The following is a description of a gene set: studied in species Mus musculus Genes up-regulated in 3T3 cells (fibroblast) upon activation of JNK pathway. from publication Han SY, Kim SH, Heasley LE (PMID 12354774) Human Gene Set: HAN_JNK_SINGALING_UP The c-Jun N-terminal kinases (JNKs) are encoded by three genes that yield 10 isoforms through alternative mRNA splicing. The roles of each JNK isoform in the many putative biological responses where the JNK pathway is activated are still unclear. To examine the cellular responses mediated by different JNK isoforms, gain-of-function JNK1 polypeptides were generated by fusing the upstream mitogen-activated protein kinase kinase, MKK7, with p46JNK1alpha or p46JNK1beta. The MKK7-JNK fusion proteins, which exhibited constitutive activity in 293T cells, were stably expressed in Swiss 3T3 fibroblasts using retrovirus-mediated gene transfer. Swiss 3T3 cells expressing either of the MKK7-JNK polypeptides were equally sensitized to induction of cell death following serum withdrawal. To search for other cellular responses that may be selectively regulated by the JNK1 isoforms, the gene expression profiles of Swiss 3T3 cells expressing MKK7-JNK1alpha or MKK7-JNK1beta were compared with empty vector-transfected control cells. Affymetrix Genechips identified genes for which expression was increased in MKK7-JNK-expressing cells relative to vector control cells. Twenty genes including those for c-Jun, MKP-7, interluekin-1 receptor family member ST2L/ST2, and c-Jun-binding protein were induced similarly by MKK7-JNK1alpha and MKK7-JNK1beta proteins, whereas genes were selectively increased by MKK7-JNK1alpha and genes were selectively increased by MKK7-JNK1beta. The set of genes selectively induced by MKK7-JNK1beta included a number of known interferon-stimulated genes (ISG12, ISG15, IGTP, and GTPI). Consistent with these gene expression changes, Swiss 3T3 cells expressing MKK7-JNK1beta exhibited increased resistance to vesicular stomatitis virus-induced cell death. These findings reveal evidence for JNK isoform-selective gene regulation and support a role for distinct JNK isoforms in specific cellular responses., and this is the list of marker genes: USP18, IFIT1B, IMPACT, SOX4, ISG15, CCND2, IFIT3, PLEKHO1, FAM3C, MAN2A1, IFI27L2, ANGPTL2, CTNND2, FOXP1, IL1RL1, CXCL10, TNC, TGFBI, DPT, LOX, EFNB2, RUNX1, JUN, CCL5, CCN1, IRF9, CD276, ZEB1, IRGM, SGK1, TNK2, SHOX2, DUSP1, DUSP16